Given this list of marker genes Slc44a2, Slc44a4, Slc5a7, Slc44a3, here is a description of the gene set: Reactome Pathway: SLC-mediated bile acid transport This event has been computationally inferred from an event that has been demonstrated in another species.<p>The inference is based on the homology mapping from PANTHER. Briefly, reactions for which all involved PhysicalEntities (in input, output and catalyst) have a mapped orthologue/paralogue (for complexes at least 75% of components must have a mapping) are inferred to the other species. species: Mus musculus part of: SLC-mediated transport of organic anions electronically inferred by orthology from the curated human pathway